The following is a description of a gene set: Reactome Pathway: Nucleotide-like (purinergic) receptors Purinergic receptors (Burnstock G, 2006; Abbracchio MP et al, 2009) are a family of newly characterized plasma membrane molecules involved in several cellular functions such as vascular reactivity, apoptosis and cytokine secretion. The functions of these receptors are as yet only partially characterized. The family includes the GPCR P2Y purinergic receptors and adenosine P1 receptors. A third family member, the P2X receptor, is a ligand-gated ion channel. part of: Class A/1 (Rhodopsin-like receptors) studied in species Homo sapiens, and this is the list of marker genes: P2RY4, GPR17, LPAR6, P2RY14, P2RY12, P2RY1, ADORA3, ADORA1, ADORA2B, P2RY10, P2RY2, P2RY6, P2RY11, P2RY13, LPAR4, ADORA2A